The following is a description of a gene set: Mouse Gene Set: GOBP_NATURAL_KILLER_CELL_ACTIVATION species: Mus musculus The change in morphology and behavior of a natural killer cell in response to a cytokine, chemokine, cellular ligand, or soluble factor., and this is the list of marker genes: Ifnab, Ifna11, Fgr, Pglyrp4, Lilrb4a, Il15, Gm13277, Coro1a, Tyrobp, Ulbp1, Lep, Mill1, Lyst, Ifna2, Fyn, Pbx1, Ifna5, Il11ra1, Ifna1, Prdx1, Stat5a, Jak2, Slamf1, Ifna14, Clnk, Tox, Sh2d1a, Fcgr4, Gm13272, Gm13276, Klrk1, Prdm1, Lgals9, Klre1, Ifnk, Il21, Rab27a, Hectd1, Ptprc, Kat7, Gm13283, H2-T23, Pibf1 (NCBI Gene Id 75821), Raet1d, Il15ra, Ifna15, Sp3, Stx11, Klrb1c, Bag6, Ifnz, Ap1g1, Klrd1, Rasgrp1, Ifnb1, Emp2, Pglyrp3, Havcr2, Il12b, Zfp683, Ifna6, Ulbp3, Gm13275, Cd2, Ncr3-ps, Ifna7, Axl, Irf1, Gm36723, Tusc2, Nkg7, Ticam1, Gm13271, Stat5b, Ifna4, Unc13d, Cd244a, Pglyrp1, Kctd9, Rabl3, Ifna13, Il18, Lamp1, Tyro3, Tyk2, Mertk, Sh2d1b2, Ifna9, Ifna12, Slamf6, Clec12a, Il12a, Ptpn22, Id2, Il18r1, Vav1, Rhbdd3, Elf4, Ifna16, Slamf7, Pglyrp2 (NCBI Gene Id 623596, peptidoglycan recognition protein 2), Zbtb1, Bloc1s6, Dcaf15, Il23a, Tcf3, Cd160, Hps1, Nfil3, Gas6, Bloc1s3, Ikzf1, Flt3l, Ifne